Given this list of marker genes Dynll1, Wrap73, Hap1, Atmin, Cenpj, Htt, Septin9, Rp1, Tmem67, Cep135, Pqbp1, Ttbk2, here is a description of the gene set: Mouse Gene Set: GOBP_POSITIVE_REGULATION_OF_NON_MOTILE_CILIUM_ASSEMBLY Any process that activates or increases the frequency, rate or extent of non-motile cilium assembly. studied in species Mus musculus